The following is a description of a gene set: Human Gene Set: GSE15624_3H_VS_6H_HALOFUGINONE_TREATED_CD4_TCELL_UP from publication Sundrud MS, Koralov SB, Feuerer M, Calado DP, Kozhaya AE, Rhule-Smith A, Lefebvre RE, Unutmaz D, Mazitschek R, Waldner H, Whitman M, Keller T, Rao A (PMID 19498172) species: Homo sapiens Genes up-regulated in CD4 T cells treated with halofuginone: 3h versus 6h. T cell differentiation to the Th17 effector subset requires stimulation through the T cell and co-stimulatory receptors, together with cytokine stimulation by TGFb and IL-6. The small molecule halofuginone (HF) inhibits Th17 cell development and induces a pattern of stress-regulated gene expression that mimics amino acid starvation. We used global transcript profiling to ask how halofuginone modulates gene expression induced during T cell activaiton and Th17 differentiation, and this is the list of marker genes: INSR, ARHGAP27, IL17RB, CLK3 (CDC like kinase 3), ZC3H11A, ARID1B, TAOK1, ABCG1, ACOT12, TSC1, ITM2C, MIR423, SLC28A2, CRIP1, HMG20A, AKAP8, ACTR1B, CRAMP1, NIPAL3, FECH (NCBI Gene Id 2235), TOGARAM1, PITPNM1, MIR668, FAM78A, S100A13, GDAP2, MAML1, RLF, TMEM108, SDC3, CDADC1, MITF, RBMS1, SFXN3, EHD1, IL1R2, MAP3K9, KMT2B, RXRA, BACE1, BIN2, TBC1D22A, MICAL1, TGM2, P2RX7, PTK2B, ASB13 (NCBI Gene Id 79754), OSBPL7, CTDSP1, ATP8B2, ARHGAP29 (NCBI Gene Id 9411), GCSAM, TMEM203, RC3H1, HOPX, MEGF9, SDCCAG8, OGFOD2, SFMBT2, KIAA0319L, EMC3, IKZF5, CENPL, BPTF, NECAP2, IL18R1, ALDH3A2, EML3, CTSD, ENTPD5, CRYBG1 (NCBI Gene Id 6763), SNAI3 (snail family transcriptional repressor 3), TGFBR3, WNK1, MAPK8IP3, MYO9B (myosin IXB), L1CAM, MBTD1, CCDC125 (NCBI Gene Id 253779), PDE7A, ATG12 (autophagy related 12, NCBI Gene Id 9140), PLEC, PDE1B, SEMA6D, CCDC88C, RETREG3, KBTBD7, IL2RB, GSN, CTSO, HSPA5, TAOK3, SPI1, FGL2, BBS2, CRIP2, C1QC, CEP164, MX1, RAB37, SYT6, PRR14, TCF7, SKAP1, S1PR4, GJC3, GNPTG, THRAP3, CCDC28A (coiled-coil domain containing 28A), ARRDC1, IFITM3, GFI1B, CEP295NL, NBEAL2, ZNRF1, RAC2, RNF138, TRAF3IP2, NR2F6, HERPUD2, LGALS9, ATP2B4, DMRTA1, CWC25, MYO1F, PRKAR2B (NCBI Gene Id 5577), UBALD1, TMEM9B, MATK, DAZAP2, CCL22, IL17RA, C6, ACOT2, GSAP, HDHD5 (haloacid dehalogenase like hydrolase domain containing 5), FUS, IQCB1, SLC22A5, CDKN2AIP (CDKN2A interacting protein), PSD4, DHX38 (DEAH-box helicase 38), SEC31A (NCBI Gene Id 51424), CPM, DDHD1, ARMCX2, SLC16A4, HAAO, CLTB, KDM4B, MXD1, MTA3, RNF20, GADD45A, TLCD4, MTMR10, WASL, ATP2B1, VCAM1, MDM4 (MDM4 regulator of p53), RNASEL, PARP16, HFE, TTYH3, PLEKHG3, INSYN2B, RNF166, ISG20, SVIL, RPS6KA5, NEDD9 (neural precursor cell expressed, developmentally down-regulated 9)